Given this list of marker genes Akap6, Camk2d, Camk2g, Chga, Hrc (histidine rich calcium binding protein), Ttn, Pde4d, here is a description of the gene set: studied in species Mus musculus Any process that modulates the frequency, rate or extent of relaxation of cardiac muscle. Mouse Gene Set: GOBP_REGULATION_OF_RELAXATION_OF_CARDIAC_MUSCLE